The following is a description of a gene set: After the virus binds to the target cell surface and is endocytosed, the low pH of the endosome causes the viral HA (hemagglutinin) to undergo a structural change which frees the fusion peptide of its HA2 subunit allowing it to interact with the endosome membrane. The transmembrane domain of the HA2 (inserted into the viral membrane) and the fusion peptide (inserted into the endosomal membrane) are in juxtaposition in the acidic pH structure of HA. The concerted structural change of several hemagglutinin molecules then opens a pore through which the viral RNP will be able to pass into the host cell cytosol. part of: Fusion and Uncoating of the Influenza Virion species: Homo sapiens Reactome Pathway: Fusion of the Influenza Virion to the Host Cell Endosome, and this is the list of marker genes: HA, PB2, NS, M, NP, PB1, NA, PA